Given this list of marker genes Ssbp4, Zfp280d, Cdk5rap3, Krt32, Cnppd1, Pnpo, Snhg17, Zfp57, Tex10, Ubr7, Rps6ka5, Cep192, Errfi1, Glis3, Parp11, Man1a2, 3110083C13Rik, Zhx2, Dusp7, C130036L24Rik, Slc7a11, Pgap1, Phf6, Irak4, Tle3, Rpia, Uqcc2, Ung, Impdh1, Phf20, Wipf2, Greb1, Crxos, 9530003O04Rik, Akip1, D030028A08Rik, Pelp1, Phf21a, Spop, Rps11, 4632404H12Rik, Gm17399, Papss2, Rabep2 (rabaptin, RAB GTPase binding effector protein 2), Dpysl2, Bcar3, Vdac1, Gm34106, Ppwd1, En1, Abca1, Tfdp1, Calr3, Gpc2, Sgce, Dhx40, Dhps, Gm4915, Nr3c1, Pllp, Tasor, Ss18, Cdip1, Shmt1, Zp1, Eif5a2, Gm3807, Igf2bp3, Kdm1b, Zmynd11, Zfp771, Tmem80 (transmembrane protein 80), 5830411K02Rik, Ino80d, Tatdn2, Plekha1, Pcmtd2, Ipp (NCBI Gene Id 16351), Mtif3, Tra2a, B230317F23Rik (NCBI Gene Id 320383), Marchf3, Ciart, Lipe, Plekhg5, Prkag2, Sox30 (NCBI Gene Id 278440), Hepacam2, Map2k6, Meiosin, Morc2a, Gas2, Tug1, Celsr2, B4galnt4, Retreg2, Virma (vir like m6A methyltransferase associated), Cdca7l, Mir7010, 2410006H16Rik, Hdac2, Unc119b, Ppm1a, Nfs1, Galnt17, Snhg15, Hmga1, Vps16, Tspan5, Snx1, Flicr, Ndc80, Vmp1, Zfp101, Atcay, Ckap5, Gpbp1, Strn3, Sec23ip, Rnf4, Micu2, 2900005J15Rik, Prodh, Tll1, Slc7a9, Ints12, Gpn3, Ddx20, Gpr180, Aida, Ift81, Safb, Smyd2, Akap13, Mir9-3hg, Zfp438, Npnt, Dpy19l1, Abl2, Mrto4, Sarm1, Nop58, Rnf2, Fam216a, 2310034O05Rik, Cwh43, Rbpms2, Tac4, Sart3, Acat1, Snx15, Lonrf3, Cmc1, Nprl2, Tcam1, Arhgap22, Fbrsl1, Stt3b, Rab8a, Ttc39a, Mrpl18, Ugp2, Rad50, 2610020C07Rik, Supv3l1, Kcnk6, Car11, Pde4a, Arpc3, Copz2, Apc, Hook1, Prpf38b, Ciao2a, Gm16580, Gpr35, Ptprs, Zfp451, Klhl35, Rasal2, Crb2, 1700112D23Rik, Stag3, Elk4, Ttc13, Osgep, Cct7, Prss36, Vps29, Inafm2, Ttc39aos1, 1700030K09Rik, Ube2q1, Timm13, Catsper2, Apex1, Mipol1, Gns, Zbtb43, Fnta, Cdyl (NCBI Gene Id 12593), Gm15234, Emc1, Myo5a, Ptp4a1, Nop56, Tdrd1, Dnajc13, Rxylt1, Mllt1, Pdia3, Eci1, Cracr2b, Pou2f1, 2310010J17Rik, Slc1a2, Tesmin, Gm815, Aph1c (aph1 homolog C, gamma secretase subunit, NCBI Gene Id 68318), Arhgdia, Pradc1, Rfx3, Psg22, Mepce, Stx4a, Chst12, Satb2, Bod1l, Zcwpw1, Kdm3a, Rabl6, Prrc2c, Gm17259, Wdr81, Romo1, Kdm5a, Snord49b, Picalm, Mtfr1l, Tbrg4, Unc13b, Ppp1r3f, 1110038B12Rik, Fbxl5, Rad9b, Snf8, Bcap29, B3gat1, Iscu, 9530080O11Rik, Lonrf2, Cenpk, Pkdcc, Inpp5b, Gchfr, Cops7a, Snora9, Cetn3, A430005L14Rik, Siglecg, Ubr4, Gm10190, Zfp747l1, Rnf6, Zfp783, A730013G03Rik (RIKEN cDNA A730013G03 gene), Usp6nl, Gm17430, Kif2a, Pif1, Ly6g6f, Cyb561d2, Igf2r, Mrc2, 5730480H06Rik, Ash2l, Clcn3, Sinhcaf, Gm10655, Tsnax, Zfp574, Adnp (NCBI Gene Id 98815), Ube2q2, Gm25489, Zcchc10, Lratd1, Mir152, Tfrc, here is a description of the gene set: from publication Yevshin I, Sharipov R, Kolmykov S, Kondrakhin Y, Kolpakov F (PMID 30445619) Mouse Gene Set: L3MBTL2_TARGET_GENES studied in species Mus musculus Genes containing one or more binding sites for (L3mbtl2) in their promoter regions (TSS -1000,+100 bp) as identified by GTRD version 20.06 ChIP-seq harmonization.